The following is a description of a gene set: Mouse Gene Set: GOMF_VINCULIN_BINDING Binding to vinculin, a protein found in muscle, fibroblasts, and epithelial cells that binds actin and appears to mediate attachment of actin filaments to integral proteins of the plasma membrane. species: Mus musculus, and this is the list of marker genes: Sorbs3, Rtcb, Coro2b, Utrn (NCBI Gene Id 22288), Tln1 (talin 1), Ctnna1, Pxn, Dag1, Dmd, Nrap, Dlc1, Synm, Actn1